Given this list of marker genes RNF166, MRPL49, STAC2, FAM216A, TSPAN6, EIF4E3, SCAI, PPP2R2B, ADAM12, CLASRP, DCAF11, SURF1, ZBTB44, DZIP1, PHF1, PML, POU2F3, SNN, CASP12, AAMDC, WDR19, PCNP, TARS2, RANBP10, MPZL2, TMEM44, ANKRD37, UPF3B, PCMTD1, PAN2, SLC25A23, SETD4, WNK1, ACAP1, PTPRA, FCGR2A, AHI1, MYO10, METAP1D, EIF4ENIF1, IL12RB2, ECI1, ATP6V0D1, DDI2, ARIH2, COG3, AKNA, ANKLE2, CD4, SAV1, COLQ, TTC33, PLA2G7, KANSL3, HEG1, UBE2D2, CNRIP1, ABCC6, FKBP1B, PKD1, ZFP14, INPP5F, RBM48, PITHD1, C19orf12, TMEM175, ATXN10, CD28, PLEKHF1, CYSLTR2, XIAP, TAFAZZIN, NDUFS2, SLC37A4, NCKAP1L, BAZ2B, ITGAE, BARHL1, RELCH, DNAJC8, SDHA, ARFIP1, WT1, MSS51, PARL, GLO1, TMIGD1, MAP3K12, EXOC6, S1PR1, CDKAL1, HEXIM2, TBX6, TDRKH, EML3, RPAIN, UIMC1, TRIM39, GINM1, TMEM62, GPR155, HDAC1, EXT1, RBMS2, METTL27, JARID2 (jumonji and AT-rich interaction domain containing 2), PPP2R1B, PIP5K1A, MANSC1, TPI1, NDUFA7, CANT1, NXF1, CFAP410, CAPN15, ALPK2, EPS8, ARID5B, TBC1D24, ACOT8, FXYD7, ZC4H2, TAF13, RNF122, DDRGK1, HSDL2, IFT46, ADIPOR2, PPP2R3C, HSPBAP1, TBXA2R (NCBI Gene Id 6915), SIRT4, NDEL1, SCO1 (synthesis of cytochrome C oxidase 1), WDR81, NFKBIE, VIPAS39, RUNDC1 (NCBI Gene Id 146923), PIGH, SIRT7, POLD4, ZNF629, IL6ST, GPI, JAK1, RFESD, CFB, MYCBP2, STARD10, IK, SLC35B3, PCGF1, NCOA1, STXBP3, METTL5, DMRTA1, IRAK1BP1, TMC4, TWNK, RPL24, POLR2A, TLR2, PDPR, MTHFD1L, RNF19A, PRXL2B, ANKRD11, MPC1, NONO (NCBI Gene Id 8253), PRDM2, DZANK1, TIPRL, DTX2, ZBTB24, RPL17, LIMS4, MCAM, TMIE, BAHD1, ARMC7, TCF3, PLEKHO1, TP53, AP1M2, CD247, KCNC2, VPS9D1, P3H1, CXXC1, FSD2, ST6GALNAC2, TACC1, RRM2B, MTCP1, ZNF354C, PPM1F, IL18RAP, ETS1, PTPRC, here is a description of the gene set: Multipotential naïve CD4+ T cells differentiate into distinct lineages including T helper 1 (Th1), Th2, Th17, and inducible T regulatory (iTreg) cells. The remarkable diversity of CD4+ T cells begs the question whether the observed changes reflect terminal differentiation with heritable epigenetic modifications or plasticity in T cell responses. We generated genome-wide histone H3 lysine 4 (H3K4) and lysine 27 (H3K27) trimethylation maps in naïve, Th1, Th2, Th17, iTreg, and natural (n)Treg cells. We found that although modifications of signature cytokine genes (Ifng, Il4, and Il17) partially conform to the expectation of lineage commitment, critical transcription factors such as Tbx21 exhibit a broad spectrum of epigenetic states, consistent with our demonstration of T-bet and IFN-gamma induction in nTreg cells. Our data suggest an epigenetic mechanism underlying the specificity and plasticity of effector and regulatory T cells and also provide a framework for understanding complexity of CD4+ T helper cell differentiation. from publication Wei G, Wei L, Zhu J, Zang C, Hu-Li J, Yao Z, Cui K, Kanno Y, Roh TY, Watford WT, Schones DE, Peng W, Sun HW, Paul WE, O'Shea JJ, Zhao K (PMID 19144320) Genes down-regulated in comparison of Th2 cells versus Th17 cells. Human Gene Set: GSE14308_TH2_VS_TH17_DN studied in species Homo sapiens